The following is a description of a gene set: studied in species Mus musculus Mouse Gene Set: GOBP_SENSORY_ORGAN_MORPHOGENESIS Morphogenesis of a sensory organ. A sensory organ is defined as a tissue or set of tissues that work together to receive and transmit signals from external or internal stimuli. Morphogenesis is the process in which anatomical structures are generated and organized. Organs are commonly observed as visibly distinct structures, but may also exist as loosely associated clusters of cells that work together to perform a specific function or functions., and this is the list of marker genes: Sox1, Myo15a, Ntn1, Gata2, Chrna9 (NCBI Gene Id 69992), Calb1, Atp2b2, Mfsd2a, Nherf1, Bax, Mfn2, Trpm1, Stau2, Tulp1, Fgf2, Ankrd24, Dzank1, Kdr, Pou2f1, Nectin3, Large1, Vangl2, Ttc8, Wdr19, Fbn2, Ush1c, Col11a1, Gbx2, Tbx3, Bmp7 (NCBI Gene Id 12162), Rs1, Rpgrip1, Prrx2, Bmp4, Tshr, Slc44a4, Grhl3, Hoxa1, Tbc1d20, Hdac2, Shroom2, Sox9, Efemp1, Neurog1, Mir124a-2 (NCBI Gene Id 723950), Triobp, Ctnnb1, Cep290, Fgf3, Sparc, Cryaa, Ahi1, Lrig1, Arid1a, Cdh23, Foxl2, Fat1, Rbp4, Vax2os, Pdgfb, Krt13, Ptn, Rp1, Osr1, Rpgrip1l, Sox2, Enpp1 (NCBI Gene Id 97628), Casz1, Mfrp, Ftx, Ttc39c (tetratricopeptide repeat domain 39C), Tenm3, Gata3, Prdm1, Hoxa2, Vsx1, Atf4, Mir182, Vsx2, Stra6, Sp3, Vhl, Sp1, Cited2, Aldh1a3, Foxe3, Wdpcp, Aqp5, Ring1, Sod1, Atoh1, Zic1, Pax6, Tmem215, Sobp, Tbx2, Col5a2, Dlx6, Rpl38, Lrig3 (NCBI Gene Id 78922), Pou3f4, Casp6, Gnat1, Tprn, Wnt5a, Dvl3, Whrn, Frs2, Kcnq4, Foxg1, Fgfr2, Thrb, Notch1, Rarg, Epha2, Stox1, Pou4f3, Vax2, Grxcr2, Samd11, Scrib, Ntrk2, Sox4, Crygb (NCBI Gene Id 12965), Abi2, Hdac1, Abr, Cabp4, Celsr1, Grk1, Edn1, Cntf, Myo7a, Ski, Foxf2, Megf11, Thy1, Otop1, Mfap5, Zhx2, Prrx1, Nr2e3, Sox12, Col8a2, Wnt1, Bbs10, Msx1, Nf1, Th, Crb1, Hpn, Lhfpl5, Jag1, Otx2, Gli2, Mapk1, Irx6, Cnga3 (NCBI Gene Id 12790), Chd7, Pcdh15, Notch2, Hipk1, Grcc10, Prkra, Bcr, Miat, Twist1, Foxi1, Phactr4, Lrp6, Six2, Gjb6, Fzd5, Naglu, Aqp1, Prox1, Rdh13, Mir23a, Dscam, Ror2, Grxcr1, Ihh, Arl6 (ADP-ribosylation factor-like 6), Col5a1, Gnat2, Fgf8, Zic3, Otx1, Ikzf1, Ppp2r3a, Spry2, Pitx3, Dvl2, Stat3, Bdnf, Nipbl, Myo6, Tcap, Fgfr1, Myo3a, Ptf1a, Foxn4 (NCBI Gene Id 243222), Irx5, Atp6v1b1, Gfi1, Ephb2, Intu, Tsku, Hcn1, Mir96, Gabrr2, Slitrk6, Mapk3, Bhlhe23, Tspan12, Col8a1, Wnt3a, Fuz, Fscn2, Ephb1, Chrna10, Lctl, Ednra, Dll1, Slc1a1, Osr2, Dlx5, Fjx1, Pitx2, Tecta, Poc5, Bcl2, Ptprm, Rpgr, Col2a1, Rest, Fasl, Ripor2, Adamts9, Cdon, Rho, Gas1, Ush1g, Vegfa, Ndp, Rac1, Crb2, Hesx1, Hmx2, Myc (NCBI Gene Id 17869), Fgf10, Itga8, Fzd2, Prkci, Pdzd7, Cthrc1, Olfm3, Lrp5, Bhlhe22, Flt1, Alms1, Tifab, Nr4a3, Meis1, Insig1, Nkx3-2 (NK3 homeobox 2), Frzb (frizzled-related protein), Kcnq1, Cyp26b1, Bbs4, Tfap2b, Gsc, Clrn1, Ift172 (intraflagellar transport 172), Pax8, Samd7, Fzd6, Rom1, Zeb1, Aldh1a1, Bak1, Clrn2, Tmie, Agtpbp1, Tbx1, Pls1, Hipk2, Gngt1, Myo3b, Sdk2, Fgf9, Tfap2a, Insig2, Sox11, Dvl1, Atp8a2, Ptk7, Six1, Man2a1, Lhx1, Mir124a-1, Ift122, Gli3, Shh, Nog, Tbx18, Nectin1 (NCBI Gene Id 58236), Hif1a (NCBI Gene Id 15251), Tshz1, Yy1, Dio3, Hmgn1, Kdm2b, Fbn1, Impg2, Six4, Gdf11, Bloc1s5, Fat3, Rorb, Prom1, Strc, Rarb, Clic5, Sdk1, Fgfr3, Mafb, Bcar3, Hmx3, Tdrd7, Eya1, Fzd3, Slc4a7, Cfh, Pde6c, Six3, Mfap2, Hoxc13, Eya4, Pax2, Mir183 (microRNA 183), Ptprq, Sox8, Nrl, Sec24b